The following is a description of a gene set: Shortening of the poly(A) tail of a nuclear-transcribed mRNA from full length to an oligo(A) length. studied in species Homo sapiens Human Gene Set: GOBP_NUCLEAR_TRANSCRIBED_MRNA_POLY_A_TAIL_SHORTENING, and this is the list of marker genes: EIF4ENIF1, PAN3, CNOT1, CNOT6L, TOB1, CNOT9, CPEB3, CNOT7, CNOT11, PABPC1, AGO2, CNOT6, BTG2, TNKS1BP1, CNOT3, POLR2G, TNRC6A, SAMD4B (sterile alpha motif domain containing 4B, NCBI Gene Id 55095), PAN2 (poly(A) specific ribonuclease subunit PAN2), TENT4A, TENT4B, CNOT2, PARN, TNRC6B (trinucleotide repeat containing adaptor 6B), CNOT4, PNLDC1, CNOT10, MLH1, ZFP36, CNOT8, SAMD4A, TNRC6C